The following is a description of a gene set: species: Homo sapiens A G protein-coupled receptor signaling pathway initiated by somatostatin binding to the somatostatin receptor (SSTR) on the surface of a target cell, and ending with the regulation of a downstream cellular process. Human Gene Set: GOBP_SOMATOSTATIN_RECEPTOR_SIGNALING_PATHWAY, and this is the list of marker genes: SSTR2, SST, SSTR4, SSTR1, SSTR3, SSTR5